Given this list of marker genes ATM, H2BC21, UIMC1, H2BC12L, POLM, MDC1, H3-4, UBE2N, H2BC5, H2AX, XRCC4, UBE2V2, RAD50, XRCC6, KAT5, BABAM2, NHEJ1, PRKDC, H4C1, NSD2, BRCA1, RNF168, POLL, BABAM1, H2BC12, DCLRE1C, BRCC3, RNF8, H2BC9, H2BC1, H2BC4, H2BC11, PIAS4, MRE11, H2BC13, TDP2, TP53BP1, LIG4, HERC2, H2BC15, NBN, ABRAXAS1 (NCBI Gene Id 84142), H2BC26, BARD1, H2BC14, XRCC5, H2BC3, RIF1, H2BC17, TDP1, PAXIP1, here is a description of the gene set: Reactome Pathway: Nonhomologous End-Joining (NHEJ) studied in species Homo sapiens The nonhomologous end joining (NHEJ) pathway is initiated in response to the formation of DNA double-strand breaks (DSBs) induced by DNA-damaging agents, such as ionizing radiation. DNA DSBs are recognized by the MRN complex (MRE11A:RAD50:NBN), leading to ATM activation and ATM-dependent recruitment of a number of DNA damage checkpoint and repair proteins to DNA DSB sites. The ATM phosphorylated MRN complex, MDC1 and H2AFX-containing nucleosomes (gamma-H2AX) serve as scaffolds for the formation of nuclear foci known as ionizing radiation induced foci (IRIF). Ultimately, both BRCA1:BARD1 heterodimers and TP53BP1 (53BP1) are recruited to IRIF, which is necessary for ATM-mediated CHEK2 activation. In G1 cells, TP53BP1 promotes NHEJ by recruiting RIF1 and PAX1IP, which displaces BRCA1:BARD1 and associated proteins from the DNA DSB site and prevents resection of DNA DSBs needed for homologous recombination repair (HRR). TP53BP1 also plays an important role in ATM-mediated phosphorylation of DCLRE1C (ARTEMIS). Ku70:Ku80 heterodimer (also known as the Ku complex or XRCC5:XRCC6) binds DNA DSB ends, competing away the MRN complex and preventing MRN-mediated resection of DNA DSB ends. The catalytic subunit of the DNA-dependent protein kinase (DNA-PKcs, PRKDC) is then recruited to DNA-bound Ku to form the DNA-PK holoenzyme. Two DNA-PK complexes, one at each side of the break, bring DNA DSB ends together, joining them in a synaptic complex. DNA-PK complex recruits DCLRE1C (ARTEMIS) to DNA DSB ends. PRKDC-mediated phosphorylation of DCLRE1C, as well as PRKDC autophosphorylation, enables DCLRE1C to trim 3'- and 5'-overhangs at DNA DSBs, preparing them for ligation. The binding of inositol phosphate may additionally stimulate the catalytic activity of PRKDC. Other factors, such as polynucleotide kinase (PNK), TDP1 or TDP2 may remove unligatable damaged nucleotides from 5'- and 3'-ends of the DSB, converting them to ligatable substrates. DNA ligase 4 (LIG4) in complex with XRCC4 (XRCC4:LIG4) is recruited to ligatable DNA DSB ends together with the XLF (NHEJ1) homodimer and DNA polymerases mu (POLM) and/or lambda (POLL). After POLL and/or POLM fill 1- or 2-nucleotide long single strand gaps at aligned DNA DSB ends, XRCC4:LIG4 performs the ligation of broken DNA strands, thus completing NHEJ. The presence of NHEJ1 homodimer facilitates the ligation step, especially at mismatched DSB ends. Depending on other types of DNA damage present at DNA DSBs, NHEJ can result in error-free products, produce dsDNA with microdeletions and/or mismatched bases, or result in translocations. part of: DNA Double-Strand Break Repair